Given this list of marker genes PHB1, HGF, GFRAL (GDNF family receptor alpha like), PINK1, AGT, F2, PIK3CA (NCBI Gene Id 5290), TNF, BECN1, RELN, PLXNB1, TNFSF11, GCNT2, AKR1C3, NTRK1, PIK3CG, CHI3L1, MYOC, ENG, CCL3, ADRA2A, SELP, TYRO3, IGF1, TPBG, GRM2, WNT16, JAK2, RGL2, PIK3AP1, PTPRJ, CSF1R, TCF7L2, CDC42, FER, NTRK2, IL1R1, MFHAS1, RYK, KDR, PROS1, TREM2, C1QTNF1, RAMP3, NEDD4 (NEDD4 E3 ubiquitin protein ligase), ITGB1BP1, FSHR (follicle stimulating hormone receptor), SEMA4D, LIN28A, F2RL1, ERFE, CCR7 (NCBI Gene Id 1236), FLT3, GAB1, NTRK3, NTS, HBEGF, MERTK, FLT1, PARK7, IL18, CALCR, ARFGEF1, CAT, ITGB1, PRKD1, NDP, NTF3, EGF, NGF, MIR199A1, HAX1, THPO, FGFR1, PTK2B, IGFBP5 (NCBI Gene Id 3488), FGF2, GPER1, TGFB1, CX3CL1, GPX1, VAV1, OSBPL8, MIR21, GATA3, SRC, PDGFRB, PDGFD, CASS4, PIK3R5, CCL5, PRKCA, HCLS1, PRR5, RTN4, MST1R, IGF2, MIR29A, NKX3-1, INSR, VAV2, NOX4, FAM110C, GH1, PDGFRA, FYN, PDGFC, FERMT2, SIRT1, PTPN6, IRS2, AMBRA1, STOX1, SESN2, ANGPT1, BAG4, SPECC1L, SERPINA12, CX3CR1, EGFR, VAV3, ADRA2B, TMEM100, TGFB2, PDGFA, MIR138-1, FGR (FGR proto-oncogene, Src family tyrosine kinase), NRXN1, F2R, SEMA3E, XBP1, VEGFB, ADRA2C, PTK2, ERBB4, EPHA8, AXL, PDPK1, AKR1C2, LEP, EXTL3, MTOR, GAS6, SEMA5A, WNT5A, C1QBP, CBL, PRR5L, TSPYL5, IL26, CCL21, DDR2, INS, CD19, CCL19, IL1B, STK3, SPRY2, RICTOR, MYORG, RAC1, EFNA5, FGFR3, TEK, ADTRP, APP, C1QTNF12, HPSE, GDF15, DCN, RET, CCDC88A, BTBD10, IAPP, KIT, CPNE1 (copine 1), PECAM1, CSF3, HCST, P2RX4, LTK, MIR675, IGF1R, CD28, UBE3A, ERBB3 (erb-b2 receptor tyrosine kinase 3), PDGFB, MYDGF (myeloid derived growth factor), VEGFA, MTDH, PTPN11 (NCBI Gene Id 84990), ADAM8, FN1, PPARD, TGFBR1, DDR1, OSM, ARRB2, UNC5B, HIP1, TXN, IRS1, FPR2, MAZ, MIR126, THBS1, RASD2, P2RY12, here is a description of the gene set: Human Gene Set: GOBP_POSITIVE_REGULATION_OF_PHOSPHATIDYLINOSITOL_3_KINASE_PROTEIN_KINASE_B_SIGNAL_TRANSDUCTION Any process that activates or increases the frequency, rate or extent of phosphatidylinositol 3-kinase/protein kinase B signal transduction. species: Homo sapiens